Given this list of marker genes MT-ATP8, MT-TG, MT-RNR1, MT-ATP6, MT-TH, MT-CYB, MT-TL2, MT-ND5, ELAC2, MRM2, RPUSD3, RCC1L, MTERF3, MT-CO1, MT-TF, TFB1M, MT-TW, MT-ND4, MT-TR, MT-TV, MT-ND2, NGRN, MT-ND3, TRUB2, MT-CO2, MRM1, MT-CO3, NSUN4 (NOP2/Sun RNA methyltransferase 4), FASTKD2, MT-TM, MRM3, TRMT10C, MT-TT, MT-TI, MT-TS2, MT-TL1, MT-TK, PRORP, MT-RNR2, MTERF4, RPUSD4, MT-TD, MT-ND4L, MT-ND1, HSD17B10, here is a description of the gene set: species: Homo sapiens Reactome Pathway: rRNA processing in the mitochondrion Mitochondrial ribosomes contain 16S rRNA (large subunit) and 12S rRNA (small subunit) that are encoded in the mitochondrial genome and produced by processing of a long H strand transcript. Enzymes encoded in the nucleus and acting in the mitochondrial matrix modify 5 nucleotides in the 12S RNA and 4 nucleotides in the 16S rRNA. part of: rRNA processing